Given this list of marker genes Fermt2, Farp2, Skap1, Fblim1, P2ry12, Rap1b, Foxc2, Cxcl13, Cd24a, Jam3, Piezo1, Rasip1, Cdh17, Kif14, Selp, Ptger4, Pcsk5, Plek, Fermt1, here is a description of the gene set: Any process that modulates the frequency, rate, or extent of integrin activation. Mouse Gene Set: GOBP_REGULATION_OF_INTEGRIN_ACTIVATION species: Mus musculus